The following is a description of a gene set: from publication Nakaya HI, Wrammert J, Lee EK, Racioppi L, Marie-Kunze S, Haining WN, Means AR, Kasturi SP, Khan N, Li GM, McCausland M, Kanchan V, Kokko KE, Li S, Elbein R, Mehta AK, Aderem A, Subbarao K, Ahmed R, Pulendran B (PMID 21743478) Human Gene Set: GSE29618_PRE_VS_DAY7_POST_TIV_FLU_VACCINE_MONOCYTE_DN Genes down-regulated in comparison of monocytes from TIV influenza vaccinee pre-vaccination versus those at day 7 post-vaccination species: Homo sapiens Systems vaccinology has emerged as an interdisciplinary field that combines systems wide measurements and network and predictive modeling applied to vaccinology. Here we used the systems vaccinology approach to study the molecular mechanisms underlying th, and this is the list of marker genes: PLAAT2, ASXL1, H2BC4, CHST3, ABCF3, SDC4, ACSS3, CD160, NR1H2, MMS19, IL22RA1, GPI, LGSN, BRAF, ARF5, NDUFB1, TRIM37, DEXI, SNAPC5, SERPINF2, NRIP2, GADD45B, MEGF8, UBR4, RANBP10, PDE6C, ZNF84, BATF, ADRA2A, KRR1, ZNF189, TAOK2, DLST, TSC22D1, ALK, NENF, NCKIPSD, PRM1, PDIA5, SNX24, ANKRD36BP2, PSD4, FFAR3, SCYL3, ROR1, IER5, IER2, MAP1LC3B, GPATCH3, NDUFAF7, FAM234B, USP14, GUSBP11, UNC119B, DNASE2B, SLC17A3, LETM1, COQ9, CLTB, TRMT9B, RIC8A, MCAT, MED20, PPIB, SAP30L, STOML1, AK5, CRAT, ELMO3 (engulfment and cell motility 3), IL16, PPM1G, TXN2, S100PBP, GPX7, FOXF2, FIRRM, ACE2, TRIP10, DDRGK1, CHFR, DIP2C, WDR43, GFM1, RPGRIP1, PTCD1 (NCBI Gene Id 26024), TRIP6, DDX24, GABRE, DGUOK, ZNF688, YIPF2, CR2, FES, CHKB, SUGP2, CEP63, BEST1, MBL1P, NECTIN2, DLGAP4, ARF4, MPL, RIPOR1, ARHGAP10, ABCD4, SYNRG, DLEU1, INPP5D, PEX14, PPOX, SRSF1, ACP6, TM9SF1, ELOVL4, GTF2H4, POLR3K, ARFGAP2, MTMR14, CTPS1, TJAP1, GCN1, ARPC5L, CD3D, TPM4, KANK3, GPR75, ARFIP2, P2RY1, MRPL17, PARM1, RNF220 (NCBI Gene Id 55182), ARR3, DAPP1, DPY19L1P1, CCL4, UST, STRN4, LNPEP, VIPAS39, SMC5, H3C8, GDF9, GTF2H2B, PJA1, SEMA3G, EEF2KMT, CCIN, USP10, CNGA3, ZBTB48, EPCAM, PIH1D1, CACNA1C, WBP2, SUPT6H, CSF2RA, CCAR2, ENPP2, PROS1, TMEM74B, PSMD3, WWP2, HSPA4L, SDHAF1, SEL1L3, MEN1, ZNHIT1, KHDC4, PRAMEF10, TMC5, OSBPL9, PRKD1, TRIM15, DYNC2I1, TRIM48, PEX12, ACO2, TNF, BMS1, FLII, ARAP3, SRSF7, HDLBP, SCN9A, COMT, SCEL, IARS1, LSM1, WDR6, SLC4A2, UBFD1, AKR1C2, HEXIM1, SARM1, BEX4, KIF23, TCHH, PRMT2, TRMT61B